The following is a description of a gene set: studied in species Homo sapiens An inability of the tubules in the kidney to reabsorb small molecules, causing increased urinary loss of electrolytes (sodium, potassium, bicarbonate), minerals, glucose, amino acids, and water. Human Gene Set: HP_RENAL_FANCONI_SYNDROME Renal Fanconi syndrome, and this is the list of marker genes: HNF1B, RRM2B, CTNS, POLRMT, IVD, BCS1L, COA8, PIGA, SLC12A3, SURF1, MT-TN, HNF4A, FAH, CLCNKB, OCRL (OCRL inositol polyphosphate-5-phosphatase)